The following is a description of a gene set: The CYP4 family are the main CYPs involved in the metabolism of long-chain fatty acids. part of: Cytochrome P450 - arranged by substrate type Reactome Pathway: Fatty acids species: Homo sapiens, and this is the list of marker genes: CYP4A11, CYP2B6, CYP2D6, CYP4F11, CYP2A13, CYP4F8, CYP4A22, CYP2F1, CYP4B1, CYP4F3, CYP4F22, CYP2A7, CYP4F12, ADH7, CYP4F2, CYP2J2